The following is a description of a gene set: Lens subluxation species: Homo sapiens Human Gene Set: HP_LENS_SUBLUXATION Partial dislocation of the lens of the eye., and this is the list of marker genes: CBS, ASPH, SF3B1, GNA11, LOXL1, CYSLTR2, P3H2, COL2A1, GNAQ, CHRDL1, COL18A1, BAP1, SALL2, PCYT1A, ELP4 (NCBI Gene Id 54515)